Given this list of marker genes SCN9A (sodium voltage-gated channel alpha subunit 9), FBXO7, SYNJ1, PINK1, SCN1B (sodium voltage-gated channel beta subunit 1), TBP, KBTBD13, SLC6A3, PDGFB, TACO1, FMR1, ENSG00000288330, PRRT2, ATXN3, ATL1, SLC20A2 (solute carrier family 20 member 2), PRDX3, KCNC3, PODXL (NCBI Gene Id 5420), ADH1C, TPM2, ATXN8OS, MT-TT, HCN1, RRM2B, PTRHD1, DNAJC6 (DnaJ heat shock protein family (Hsp40) member C6), ATXN10, TPM3, HTT, PTPA, COASY, EIF2AK2, GABRA1, GCH1, MYORG, SLC2A3, EIF2AK1, SLC39A14, KLHL41 (kelch like family member 41), PRKN, PARK7, GABRG2, EIF4G1, MECP2, SLC25A4, PLA2G6, SLC30A10, SPR, ATP5MK, UBAP1, NR4A2 (NCBI Gene Id 4929), CLTC, VPS35, VPS13C, PET117, ATXN2, AHDC1, PRKRA, DCTN1, GIGYF2, ATCAY, SCN1A, HTRA2, FGF13 (NCBI Gene Id 730528), PCDH19, WDR45, PRKAR1B, PDE8B, JPH3, TH, EARS2, GABRD, PANK2, PTS, UCHL1, RAB39B, SNCAIP, ATP1A3, PRNP, TSPOAP1, CSF1R, JAM2, DNAJC12, TTC19, UQCRC1, DNAJC13 (NCBI Gene Id 285196), FARS2, ATP13A2, MAPT, STX1B, ADGRV1, TAF1, ATXN1, TENM4, LRRK2, GBA1, TK2, ACTA1, KCNN2, MYPN, TWNK, DHDDS, FTL, CHCHD2, IMPDH2, PPP2R2B, POLG, COQ2, PDGFRB, SCN2A, ATP6AP2, POLG2, PIDD1, NEB (NCBI Gene Id 4755), VPS13A, SNCA, here is a description of the gene set: Bradykinesia species: Homo sapiens Bradykinesia literally means slow movement, and is used clinically to denote a slowness in the execution of movement (in contrast to hypokinesia, which is used to refer to slowness in the initiation of movement). Human Gene Set: HP_BRADYKINESIA